The following is a description of a gene set: Any process that results in a change in state or activity of a cell or an organism (in terms of movement, secretion, enzyme production, gene expression, etc.) as a result of a fluoride stimulus. Human Gene Set: GOBP_RESPONSE_TO_FLUORIDE species: Homo sapiens, and this is the list of marker genes: FIS1, PLCB1, ASPN, ATG5, COL1A1